Given this list of marker genes CA5A, ACO1, CA11, AMT, CA6, UROS, HADHA, PTS, PCBD1, CBS, CA4, ACADM, ECH1, CPS1, HAL, CA8, FH, ECHS1, ACADVL, ACO2, HADHB, GLUD1, ACADSB, EHHADH, CA2, here is a description of the gene set: Nitrogen metabolism. studied in species Homo sapiens Human Gene Set: MODULE_343